Given this list of marker genes TPK1, MLYCD, PDHA2, PDHX, PDK3, PGK1, PDK4, ACLY, DIP2A, ACAT1, PDHB, PDK1, MPC2, ACSS2, PDK2, ACSS1, DLD, PDHA1, DLAT (dihydrolipoamide S-acetyltransferase), BCKDK, PPCS, here is a description of the gene set: The chemical reactions and pathways resulting in the formation of acetyl-CoA, a derivative of coenzyme A in which the sulfhydryl group is acetylated. Human Gene Set: GOBP_ACETYL_COA_BIOSYNTHETIC_PROCESS species: Homo sapiens